The following is a description of a gene set: studied in species Mus musculus Human Gene Set: CUI_TCF21_TARGETS_UP Mouse mutations have provided tremendous insights into the molecular basis of renal and glomerular development. However, genes often play important roles during multiple stages of nephrogenesis, making it difficult to determine the role of a gene in a specific cell lineage such as the podocyte. Conditional gene targeting and chimeric analysis are two possible approaches to dissect the function of genes in specific cell populations. However, these are labor-intensive and costly and require the generation, validation, and analysis of additional transgenic lines. For overcoming these shortcomings and, specifically, for studying the role of gene function in developing glomeruli, a technique to isolate and purify glomeruli from murine embryos was developed. Combined with gene expression profiling, this method was used to identify differentially expressed genes in glomeruli from Pod1 knockout (KO) mice that die in the perinatal period with multiple renal defects. Glomeruli from early developing stages (late S-shape/early capillary loop) onward can be isolated successfully from wild-type and KO kidneys at 18.5 d postcoitus, and RNA can readily be obtained and used for genome-wide microarray analysis. With this approach, genes that are differently expressed between glomeruli from Pod1 KO and wild-type mice were identified, including a four-fold reduction of alpha 8 integrin mRNA in glomeruli from Pod1 KO mice that was confirmed by immunostaining. This procedure may be adapted to any transgenic strain, providing a rapid and efficient method to dissect the function of specific genes in glomerular development. from publication Cui S, Li C, Ema M, Weinstein J, Quaggin SE (PMID 16207825) Genes most strongly up-regulated in kidney glomeruli isolated from TCF21 knockout mice., and this is the list of marker genes: FAP, VCAN, CLDN9, HJURP, NCAM1, HOMER2, STARD10, PENK, MEG3, MDK, PHGDH, COL8A2, EPHA4, HDAC11, CDKN1B (cyclin dependent kinase inhibitor 1B), DCN, CDH6, PTN, CCND2, SOX11, CLDN6, RBP1, LBP, CFH, COL6A2, IGDCC4, HMMR, COL6A1, SERPINF1, CYP7B1, LHFPL2, ISLR, LUM, CADM1, COL3A1, IGFBP2